Given this list of marker genes MCUB, RNU6-205P, CYP2U1-AS1, RBMXP4, RNU6-733P, KRT19P3, AP1AR, HADH, ZACNP1, MIR297 (microRNA 297), ALPK1 (NCBI Gene Id 80216), EGF, ENSG00000251081, ETNPPL (NCBI Gene Id 64850), RCC2P8, RNU6-289P, LYPLA1P2, FAM241A (family with sequence similarity 241 member A), RN7SL55P (NCBI Gene Id 106479244), ZBED1P1, CYP2U1, RAC1P5, RNU6-551P, TOX4P1, EXOC7P1, NEUROG2, PANCR, LEF1, OSTCP4, LRIT3, ENSG00000251126 (novel transcript, antisense to ANK2), ELOVL6 (ELOVL fatty acid elongase 6), RPL34-DT, MIR302A, H3P14, RPL36AP19, MIR302CHG, RPL7L1P13, RPSAP34, LINC01438, COL25A1-DT, RPL23AP94, RPL34, MIR8082, DKK2, GAR1, RPL36AP23, ZNF969P, RTEL1P1, MIR367, NEUROG2-AS1, LINC02945, GET1P1, ENSG00000303157, ANK2, CCDC34P1, GAR1-DT, LEF1-AS1, PITX2, RNU6-431P, ENSG00000199894, RNF14P2 (NCBI Gene Id 116435284), RNU6-35P, MIR302D, TIFA, ZGRF1, SETP20, MIR576, LARP7, OSTC (oligosaccharyltransferase complex non-catalytic subunit), ENPEP, TUBB8P3, ANK2-AS1, MIR1243, CASP6, MIR302C (microRNA 302c), RPL32P13, COL25A1, SGMS2, CDC42P4, SEC24B-AS1, SEC24B, RN7SL275P, CFI, ENSG00000248656, HIGD1AP14, RPL7AP30 (NCBI Gene Id 441034), MIR302B, RRH, PLA2G12A, HSBP1P2, AP1AR-DT, PAPSS1, ACTR6P1, here is a description of the gene set: Human Gene Set: chr4q25 studied in species Homo sapiens